The following is a description of a gene set: Mitochondrial protein degradation studied in species Homo sapiens Human Gene Set: REACTOME_MITOCHONDRIAL_PROTEIN_DEGRADATION, and this is the list of marker genes: ECH1, UQCRC2, COX5B, OPA1, HMGCS2, OXCT1, DBT, FECH, ACADSB, HSPA9, MT-CO1 (mitochondrially encoded cytochrome c oxidase I), CS, MRPL32, SLC25A5, MT-ND2, MT-ND5, ATP5F1B, PRKACA, ATP5F1A, MT-ND1, ME2, LONP1 (NCBI Gene Id 9361), BDH1, MRPS2, ACO2, NDUFB6, AFG3L2, MT-ND6, NDUFA13, NDUFS1, IDH2, PDK1, TRIAP1, ACAD8, HSD17B10, TIMM10, TFAM, ALDH2, PMPCA, IDH3A, ARG2, STAR, NDUFV3, HTRA2, NADK2 (NCBI Gene Id 133686), OGDH, NDUFA2, FH, ATP5F1C, ACAT1, PRELID1, OXSM, PCCB, TIMM22, IARS2, ALAS1, CLPX, MDH2, ATP5PD, ATP5PF, SMDT1, TIMM17A, COX5A, PDHA1, SSBP1 (single stranded DNA binding protein 1), MT-CO2, ATP5PO, MICU2 (NCBI Gene Id 221154), CLPP, HADH, SPG7, CHCHD2, STARD7, TWNK, SLC25A6, PDHB, HSPD1, LDHD, NDUFS3, OMA1, NDUFV1, ATP5MG, ECI1, ALDH1B1, APP, SHMT2 (serine hydroxymethyltransferase 2), YME1L1, MT-ATP6, ALDH18A1, COX4I1, MRPS10, UQCRQ, SUCLG2, TIMM9, GLUD1, DLD, ACOT2, MRPL12